The following is a description of a gene set: Mouse Gene Set: MIR_7226_3P Genes predicted to be targets of miRBase v22 microRNA mmu_miR_7226_3p in miRDB v6.0 with MirTarget v4 prediction scores > 80 (high confidence targets). species: Mus musculus from publication Chen Y, Wang X (PMID 31504780), and this is the list of marker genes: Lmo3, Cdyl2, Ece1, Eea1, Cygb, Arhgap36, Poglut3, Cyria, Hipk1, Serpina3c, Adamtsl1, Ptpn5, Zmat4, Tal1, Wipf1, Pianp, Crmp1, Bcor, Spink5, Fermt3, Zfp280c, Col4a2, Hdgfl3, Onecut2, Brsk1, Mpv17, Mfap3l, Hdlbp, Mgme1, Dhcr24, Serp2, Slc22a5, Atp6ap2, Wdr55, Tnrc6b, Zeb2 (zinc finger E-box binding homeobox 2), Amigo1, Dcaf7, Spice1, Grm1, Mcts1, Zbtb43, Dcstamp (dendrocyte expressed seven transmembrane protein), Ubash3b, Dppa1, Shisal1, Tshz1, Zfyve27, Plekha6, AI182371, Vps26b, Fst, Tph2, Prox1, Psd2, Coq3, Atp1a3, Epm2aip1, Chrna4, Glcci1, Vat1, Them7, Itga9, Mxd1, Vti1a, Aff4, Flt4, Thrb, Atg3, Sh3bgr, Elovl5, Arrdc4 (NCBI Gene Id 66412), Mdm4, Zmat3, Cdh11, Sde2, Atp11a, Arfrp1, Arhgap21, Ptprn2, Phf6, Kmt2a, Oaz2, Elk3, Cab39, Napb, Klhl1, Ppp2r1a, C2cd5, Zfp346, Clk4, Mcfd2, Ttc39b, Zfp653, Otud4, Itgal, Atp8a1, Spata31d1c, Gcnt2, 1700067P10Rik, Gria4, Tmpo, Gnl1, Zc3h12c, Npc1, Ptp4a2, Fyb1, Arhgap42, Zik1, Hadhb, Slc23a2, Ak5, Herc2, Zfp449, Slc45a4, Atp1b2, Kcna2, Hipk3, Cxxc5, Tnni1 (troponin I, skeletal, slow 1), Larp4b, Tmem204, Depdc7 (NCBI Gene Id 99275), Cacfd1, Smg1, Nfasc, Epha10, Dip2c, Pnkd, Sap130, Kif9, Rab9b, Pgpep1, Chrna2, Camsap1, Clnk, Zfp26, Nipal2, Ppp2r2a, Plekhh1 (NCBI Gene Id 97792), Zfp474 (zinc finger protein 474), Trip12, Ulk1, Snx3, Ccdc97, Ildr2, Yipf4, Ptrhd1, Fmr1, Tbcel, Usp9x, Fgf10, Kcnq3, Rilpl2, Gpcpd1, Foxo4, Wdfy3, Fkbp1b, P2rx3, Tac1, Fbxo42, Rora, Plekhh2, Wdr6, Tcf12, Smok3a, Kif3a, Cep128, Paip1, Mcemp1, Cpne8, Fanca, Gbp3, Donson, Itgav, Oxtr, Sgta, Pgap4, Ajap1, Grhl3, Lsm11, Grik2, Col2a1